Given this list of marker genes Sox18, Acvr2b, Tie1, Nr2f2, Bmpr2, Pdpn, Prox1, Acvrl1, here is a description of the gene set: species: Mus musculus The process in which a venous blood vessel endothelial cell acquires specialized features of a lymphatic vessel endothelial cell, a thin flattened cell that lines the inside surfaces of lymph vessels. Mouse Gene Set: GOBP_LYMPHATIC_ENDOTHELIAL_CELL_DIFFERENTIATION